Given this list of marker genes DYRK3, PRKCG, DYRK1A, TESK2, CLK1, RPS6KA1 (ribosomal protein S6 kinase A1), CLK2, MAPKAPK3, MAP2K4, PRKAA2, AURKC, PBK, TESK1, MAP2K3, DSTYK, RPS6KB1, PRKACA, MAP3K9, MAPK9, MAPK14, BRAF, AURKA (NCBI Gene Id 8465), MAP2K2, MAP2K5, CLK3, MAP2K1, SBK2, PAK3, MAPKAPK5, DYRK1B, DYRK4, TTK, AKT1, AURKB, CLK4, ACVR2B, RPS6KA2, MAP2K7, MAP2K6, TNK2, SGK1, DYRK2, MAPK10, here is a description of the gene set: Catalysis of the reactions: ATP + a protein serine = ADP + protein serine phosphate; ATP + a protein threonine = ADP + protein threonine phosphate; and ATP + a protein tyrosine = ADP + protein tyrosine phosphate. Human Gene Set: GOMF_PROTEIN_SERINE_THREONINE_TYROSINE_KINASE_ACTIVITY studied in species Homo sapiens